Given this list of marker genes ATP6V1H, ptpA, here is a description of the gene set: Acidification of the phagosome occurs by insertion of ATPases into the phagosomal membrane in preparation for fusion with lysosomes. The pH of phagosomes containing Mtb never drops below 6.5 due to Mtb interfering with several acidification mechanisms. part of: Suppression of phagosomal maturation species: Homo sapiens Reactome Pathway: Blockage of phagosome acidification